The following is a description of a gene set: Human Gene Set: GOBP_MICROGLIA_DIFFERENTIATION The process in which a relatively unspecialized cell acquires specialized features of a microglial cell. Microglia are glial cells that act as the immune cells of the central nervous system. They form part of the supporting structure of this system. studied in species Homo sapiens, and this is the list of marker genes: APP, GBA1, NRROS, VPS54, TGFB1, VPS13A, MYD88, TLR2, MFSD8, TSPAN2, TLR4, NR3C1, QKI, NAGLU, CCDC39, NDP